Given this list of marker genes DHFR, TGFA, NME1, TUBB2A, HMMR, HJURP, MCM10, DNAJC9, MSH2, BUB1B, DEPDC1, MCM6, PCNA, PSMC3IP, CEP55, CDCA8, UCK2, ENO2, NUSAP1, SLC43A3, NAP1L1, SMC4, TIMELESS, KIF18B, TUBB4B, TTK, PA2G4, RANGAP1, IER3, OASL, ASF1B, SNRPD1, NCAPG2, SLC20A1, TYMS, PARP2, HSPA14, ECT2, ETV5, KIF2C, POLA2, KIF15, ORC6, DLGAP5, E2F8, RFC2, MAFF, DPAGT1, ZC3HAV1, CCNB1, TOP2A, PHLDA2, AREG, PRPS1, IL11, STEAP1, CCNE2, H4C3, CTPS1, NAA15, CENPU, GINS3, GINS1, PRIM1, SRM, ELL2, GINS2, TFDP1, DDX39A, HMGA2, DUSP6, MCM3, MCM4, SPHK1, H2AZ1 (H2A.Z variant histone 1), CDC6, SNRPA1, CDCA3, DUSP4, CKS2, ITGA6, EEF1E1, POLR3K, AXL, SMC2, CDK2 (cyclin dependent kinase 2), EXOSC8, AURKA, CHAF1A, LMNB2, GALNT10, CCND1, ERCC6L, CENPM, CDC45, RNASEH2A, ORC1, RFWD3, STIL, VRK1, ZWINT, FABP5, PIMREG, GTSE1, SLCO4A1, PBK, CDC20, RRP15, TUBB6, DSCC1, TNFRSF6B, CCND3, DUT, CDCA4, PSAT1, CENPN, ABCE1, HMGB2, CX3CL1, SHCBP1, NEMP1, PUS7, FAM216A, PAICS, GMNN, UBE2C, RANBP1, WWTR1, RACGAP1, DUSP5, NOLC1, CCNA2, NOC3L, DONSON (NCBI Gene Id 55597), BLM (BLM RecQ like helicase), NDC80, RFC3, SPDL1, MSH6, FAM111A, TCOF1, ETV1, NOP56 (NOP56 ribonucleoprotein), NRG1 (neuregulin 1), NCAPD3, TUBG1 (NCBI Gene Id 7283), SLC29A1, MCM5, USP1, ADORA2B (NCBI Gene Id 136), NEK2, GPSM2, PLK4, CDT1 (NCBI Gene Id 81620), MCM7, ZWILCH (NCBI Gene Id 55055), BRCA1, CCNF (NCBI Gene Id 899), KPNA2, SRSF7, HNRNPDL, KIF4A, TUBA1A, POLR2D, BUB1, ASPM, TPX2, DKK1, DSN1, CKS1B, CSE1L, MYBL2, EXO1, FANCI, BIRC5, POLA1, MAD2L1, NT5E, NUDT15, MET, TMEM158, NETO2, TUBB, KIF23, RFC5, CARD10, FEN1, DBF4, TCN1, SPRED2, PLK1, TMPO, CDKN3, STC1 (stanniocalcin 1), DTL, AURKB, NCAPH, GJB3, CENPA, TREX2, CDK1, KIF11, ODC1, E2F1, ACOX2, UPP1, TIPIN, UNG, CDC42EP1, CKLF, SPAG5, SPC25, MELK, RAD54B, RRM1, HELLS, NCAPG, TEX30, TNFRSF12A, RAD51, FOSL1 (FOS like 1, AP-1 transcription factor subunit), POLE2, BARD1, H2AX, RRM2, PRC1, CMC2, LMNB1, HAT1, ATAD2, RFC4, UBE2S (ubiquitin conjugating enzyme E2 S), G0S2, KIF14, PNN, MKI67, PSRC1, TRIP13, SOX9, MYBL1, CDC25A, EZH2, ESPL1, PPIF, RMI1, PKMYT1, DCBLD2, TFPI2, EREG, MCM2, RAD51AP1, TK1, here is a description of the gene set: Genes down-regulated in H1975 cells (non-small cell lung cancer, NSCLC) resistant to gefitinib after treatment with EGFR inhibitor CL-387785 for 24h. from publication Kobayashi S, Shimamura T, Monti S, Steidl U, Hetherington CJ, Lowell AM, Golub T, Meyerson M, Tenen DG, Shapiro GI, Halmos B (PMID 17145885) Human Gene Set: KOBAYASHI_EGFR_SIGNALING_24HR_DN Activating mutations in the epidermal growth factor receptor (EGFR) tyrosine kinase domain determine responsiveness to EGFR tyrosine kinase inhibitors in patients with advanced non-small cell lung cancer (NSCLC). The modulation of transcriptional pathways by mutant EGFR signaling is not fully understood. Previously, we and others identified a single base pair change leading to a threonine to methionine (T790M) amino acid alteration in the ATP-binding pocket of the EGFR as a common mechanism of acquired resistance. The gefitinib-resistant, T790M-mutant H1975 NSCLC cell line undergoes prominent growth arrest and apoptosis when treated with the irreversible EGFR inhibitor, CL-387,785. We did a transcriptional profiling study of mutant EGFR target genes that are differentially expressed in the resistant gefitinib-treated and the sensitive CL387,785-treated H1975 cells to identify the pivotal transcriptional changes in NSCLC with EGFR-activating mutations. We identified a small subset of early gene changes, including significant reduction of cyclin D1 as a result of EGFR inhibition by CL-387,785 but not by gefitinib. The reduction in cyclin D1 transcription was associated with subsequent suppression of E2F-responsive genes, consistent with proliferation arrest. Furthermore, cyclin D1 expression was higher in EGFR-mutant lung cancer cells compared with cells with wild-type EGFR. EGFR-mutant cells were routinely sensitive to the cyclin-dependent kinase inhibitor flavopiridol, confirming the functional relevance of the cyclin D axis. These studies suggest that cyclin D1 may contribute to the emergence of EGFR-driven tumorigenesis and can be an alternative target of therapy. species: Homo sapiens